The following is a description of a gene set: Mouse Gene Set: CUI_T_CELL_CD4_EGF_RESPONSE_DN species: Mus musculus Genes negatively differentially expressed in cell type: CD4+ T cell upon treatment with cytokine: EGF in mouse lymph nodes in vivo. Cytokines mediate cell-cell communication in the immune system and represent important therapeutic targets. A myriad of studies have highlighted their central role in immune function, yet we lack a global view of the cellular responses of each immune cell type to each cytokine. To address this gap, the authors created the Immune Dictionary, a compendium of single-cell transcriptomic profiles of more than 17 immune cell types in response to each of 86 cytokines (>1,400 cytokine-cell type combinations) in mouse lymph nodes in vivo. A cytokine-centric view of the dictionary revealed that most cytokines induce highly cell-type-specific responses. For example, the inflammatory cytokine interleukin-1β induces distinct gene programmes in almost every cell type. A cell-type-centric view of the dictionary identified more than 66 cytokine-driven cellular polarization states across immune cell types, including previously uncharacterized states such as an interleukin-18-induced polyfunctional natural killer cell state. from publication Cui A, Huang T, Li S, Ma A, Pérez JL, Sander C, Keskin DB, Wu CJ, Fraenkel E, Hacohen N (PMID 38057668), and this is the list of marker genes: Bcl2, Ppp1r15a, Tsc22d3, Junb, Klf6, Klf2